The following is a description of a gene set: Human Gene Set: WP_G_PROTEIN_SIGNALING G protein signaling species: Homo sapiens, and this is the list of marker genes: GNB1, AKAP8, GNG12, GNG5, GNA11, GNG13, KRAS, GNB2, AKAP5, GNAQ (NCBI Gene Id 2776), PRKCG (NCBI Gene Id 57013), ADCY2, ADCY4, PDE4D, PRKD3, GNAZ, PDE8B, AKAP10, PRKACG, PRKCZ, PRKCQ, PDE7A (NCBI Gene Id 5150), ADCY3, GNA15, PDE1A (NCBI Gene Id 5136), AKAP13, PRKACA, AKAP3, PDE8A, KCNJ3, PRKCA, GNAI1, PRKAR1B, GNAO1, PRKCH, AKAP7, GNGT1, PDE1C, PDE4A, GNAS, ADCY6, GNG3, GNG8, RHOA, ARHGEF1, PRKAR2A, GNAI3, GNAL, AKAP4, GNB5 (NCBI Gene Id 82962), GNA12, PDE7B, PLCB3, PRKAR1A, AKAP12, NRAS, HRAS (NCBI Gene Id 338029), PPP3CA, ADCY1, PPP3CC, ADCY8, GNGT2, GNB3, GNA13, GNG10, AKAP1, GNG4, PRKCE, RRAS (RAS related), GNG11, GNA14, PRKACB, PDE1B, CALM1 (NCBI Gene Id 801), PRKCD, PRKAR2B, PDE4C, AKAP11, ADCY5, PRKD1 (NCBI Gene Id 5587), ADCY7, AKAP9, ADCY9, PDE4B, SLC9A1, ITPR1, GNAI2, GNG7, AKAP6, PRKCI, PRKCB